The following is a description of a gene set: Mouse Gene Set: MP_INCREASED_PLASMACYTOMA_INCIDENCE studied in species Mus musculus from publication Motenko H, Neuhauser SB, O'Keefe M, Richardson JE (PMID 26092688) Mouse genes annotated to increased plasmacytoma incidence (MP:0010286) retrieved from the Mouse Genome Informatics database via MouseMine, and this is the list of marker genes: Il12rb2, Foxn1, Abl1, Becn1, Fdxr